The following is a description of a gene set: Human Gene Set: HP_RECURRENT_PANCREATITIS species: Homo sapiens A recurrent form of pancreatitis. Recurrent pancreatitis, and this is the list of marker genes: CAV1, MT-TQ, PRSS2, MT-ND6, GCGR, MT-TF, MT-CO3, MT-ND5, SPINK1, MT-TW, MT-CO1, CTRC, CFTR, MT-ND4, GPIHBP1, MT-TS2, MT-ND1, CPA1, TRPV6, PRSS1, CDC73, CCDC47, MT-TH, CASR, MT-TL1, MT-CO2